The following is a description of a gene set: from publication Szanto A, Balint BL, Nagy ZS, Barta E, Dezso B, Pap A, Szeles L, Poliska S, Oros M, Evans RM, Barak Y, Schwabe J, Nagy L (PMID 21093321) studied in species Homo sapiens Conditional macrophage-specific PPARg knockout mice were generated on C57Bl/6 background by breeding PPARg fl/- (one allele is floxed, the other is null) and lysozyme Cre transgenic mice. PPARg and IL-4 signaling was analyzed on bone marrow-derived macrophages. Bone marrow of 3 mice per group was isolated and differentiated to macrophages with M-CSF (20 ng/ml). 20 ng/ml IL-4 was used to induce alternative macrophage activation and 1 uM Rosiglitazone (RSG) was used to activate PPARg. From each mouse 4 samples were generated: 1. M-CSF, 2. M-CSF+RSG, 3. IL-4 and 4. IL-4+RSG. All compounds were added throughout the whole differentiation process, and fresh media was added every other day. Control cells were treated with vehicle (DMSO:ethanol). After 10 days, RNA was isolated and gene expression profiles were analyzed using Mouse Genome 430 2.0 microarrays from Affymetrix. Human Gene Set: GSE25123_CTRL_VS_ROSIGLITAZONE_STIM_MACROPHAGE_UP Genes up-regulated in wildtype bone marrow-derived macrophages: control versus treated with rosiglitazone., and this is the list of marker genes: FAM117A, WDR46, CNOT3, PTK2B, STRIP1, LMNB1, RECQL4, PPP1R18, COX15, ELF2 (NCBI Gene Id 1998), CFAP410, ADAM8, USP22, CCR7, UBE2D2, CSK, AKT3, STK40, ABHD1 (NCBI Gene Id 84696), WDR83OS, HLA-E, FANCE, SUDS3, EGR3, STAT5B, NYAP1, MARK3 (NCBI Gene Id 4140), ERP29, KLHL18, PPP1R14B, CLTA (NCBI Gene Id 63271), ZHX2, TCP11L2, ACTR1B, RCC2, CALCOCO1, CREG1, RTL8B, UBE2R2, GPX4, EPHX1, PER1, TXNDC11, GPR132, PIK3R4, KDM2A, FOS, ZNF467 (zinc finger protein 467), CAPZB, DGAT1, CITED2, LZIC, NCOA7 (NCBI Gene Id 135112), ANKRD13D, FZD5, CCDC85B, MRPS24, KAZALD1, MAPK6, ADIPOR1, PRAMEF8 (NCBI Gene Id 729516), PRKCQ, SF3B4, DIP2B, TLE3, KLHL36, TRIM11, GPR18, SNORD104, TMEM115, STS, TBC1D22B, NSMCE3, OTUD7B, AKNA, EVL, ASS1, RBM22, GLIPR2, CTNNBIP1, AUH, TLE2, TBL1X, AP2B1, TMEM81, PHPT1, HSPBAP1, MAD1L1, ZNF131, IL17RA, PLEKHJ1, TSG101, TNFRSF1A, LIPE, DCAF8, YJU2, MTURN (NCBI Gene Id 222166), SUOX, STAT6, LRRC41, DUSP5, LIN7C, ZXDB, CHRNE, SETD5, FHOD1, PPP1R37, NCSTN, PBX2, ARPC1A, SNRNP70, AMFR, SMG8, MGAT2, DDIT4 (DNA damage inducible transcript 4), ZNF689, ISCU, EIF5A, PPDPF, CHIC2, CYTH1, DTX3, SAMHD1, MSL2, PARP6, FBXL20, UBE2T, MAX, EGR1 (early growth response 1), EYA3, DDX27, CFAP141, ZNF362, CEP250, METRN, HSP90AB1, PAFAH1B1, AGER, C1orf122, LY9, PABPC4, PSME3, IRS2, STARD10, MORN2, PELO, EGR2, CNNM3, SEPTIN9, JUP, CEBPB, JUNB, PRR12, YPEL5, ELK4, MTA2, RPL18, DGKQ, AP2A1, TP53I11, MCRIP2, LETMD1, UBOX5 (NCBI Gene Id 494512), MAZ, DLGAP4, LGMN, SARS1, FRG1, ARF5, SLC25A39, GIGYF2, ATP5F1B, ALG2, GCA, CTDNEP1, KBTBD2, ZFP90, UAP1, BCAT2, APOBEC3B, GLYR1, SLC25A3, GALNT6, SLC9A9, TTC5 (NCBI Gene Id 91875), EPB41, RAB5C, CD37, PACSIN1, SLC25A51, PATZ1, MBD6, DOK1, ITGA5, SCAF1, CBLB, RNF167 (ring finger protein 167), TSC22D4, SHC1